The following is a description of a gene set: studied in species Mus musculus The process in which a relatively unspecialized cell acquires the specialized features of a pericyte cell. Mouse Gene Set: GOBP_PERICYTE_CELL_DIFFERENTIATION, and this is the list of marker genes: Foxc2, Gpr4, Pdgfb, Tgfb2 (transforming growth factor, beta 2), Wnt4, Acta2, Cd34 (NCBI Gene Id 98592), Notch1, Osr1, Bmp4, Epha2, Spi1